Given this list of marker genes COL9A3 (collagen type IX alpha 3 chain), ASPH, PDE6B, H4C5, H4C3, BBS2, FLNA, here is a description of the gene set: Moderate myopia Human Gene Set: HP_MODERATE_MYOPIA studied in species Homo sapiens A moderate form of myopia with refractive error of between -3.00 and -6.00 diopters.